Given this list of marker genes NHERF1, ANKRD24, PDZD7, PAFAH1B1, SEC24B, LHFPL5, CLRN2, SCRIB, TPRN, FGFR1, CLRN1, WDPCP, WHRN, RAC1, MYO7A, CDH23, STRC, SOD1, KCNQ1, TRIOBP, SLC4A7, SLITRK6, GRXCR2, USH1C, TECTA, PLS1, TMC1, REST, GRXCR1, ELMOD3, here is a description of the gene set: The process whose specific outcome is the progression of an auditory receptor cell over time, from its formation to the mature structure. Cell development does not include the steps involved in committing a cell to a specific fate. Human Gene Set: GOBP_AUDITORY_RECEPTOR_CELL_DEVELOPMENT studied in species Homo sapiens